Given this list of marker genes RAPGEF3, EEF2K (eukaryotic elongation factor 2 kinase), P2RY2, P2RY12, FBP1, DMTN, DGKQ, TRPA1, SREBF1, P2RX2, HCN4, ATP5PO, TLR7, KCNQ1, KCNJ11, SLC26A3, SSH1 (NCBI Gene Id 54434), TMEM38B, P2RX5, AREG, ADORA2A, RAP1A, NT5E, CRTC3, THBD, ADORA1, TRPC3, CPS1, RAP1B, AQP8, RAP1BL, CNGA3, PER1, MMP19, CFTR, CREB1, TMEM38A, HCN3, TOP2B, GATA1, TYR, STAT1, RELA, P2RX6, ZFP36L1, RYR1, RYR3, OXT, ENPP1, SLC6A3, P2RX1, GSTM2, ADIPOQ, PDXP, XRN1, AQP1, SLC5A5, TAF1, CARM1, P2RY4, AANAT, HDAC2, AHR, PENK, ITPR2, SOD1, IL1B, COL1A1, STC1, CACNA1S, WNT10B, SLC8A1, CAD, AKAP6, RAPGEF1, KCNJ8, ABCC9, KCNE1, AKAP9, P2RY11, DNTT, REN, P2RX3, APP, AQP9, ASS1, PRKAA1 (protein kinase AMP-activated catalytic subunit alpha 1), TRPM4, ATF1, CRHBP, SLC26A6, CITED1, P2RX4, PDE2A, HSP90B1, EZR, NDUFS4, CRTC1, PDE3A, ASPH, INHBB, CDO1, DUOX2, SLC6A4, SELENON, GPD1, ADSS2, VGF, BIRC2, RAPGEF2, DUSP1, SRD5A1, CIB2, KDM1A, PDE4D (phosphodiesterase 4D), PNPT1, DUOX1, RYR2, CASQ2, PIK3CG (phosphatidylinositol-4,5-bisphosphate 3-kinase catalytic subunit gamma), FOS, IGFBP5, HMGCS2, TRPV1, TOP1, WT1, INPP5K, FOSB, FDX1, PANX1, ADA, TIFAB, GUCD1, SCX, TRPM2, ALAS1 (5'-aminolevulinate synthase 1), SLC8A3, P2RX7, PKLR, NPR2, PKD2, AKAP7, P2RY6, GNAL, P2RY1, HCN2, BSG, HCN1, CRTC2, here is a description of the gene set: Any process that results in a change in state or activity of a cell or an organism (in terms of movement, secretion, enzyme production, gene expression, etc.) as a result of a purine-containing compound stimulus. species: Homo sapiens Human Gene Set: GOBP_RESPONSE_TO_PURINE_CONTAINING_COMPOUND